Given this list of marker genes LIMCH1, PPM1E, RHPN1, BRAF, RHOC, NF2, SDC4, TAC1, ARHGAP6, TMEFF2, ITGB5, TNFAIP1, EVL, WASF2, RHOA, AMOT, SFRP1, OAZ3, INPP5K, CUL3, PHLDB2, MIR21, S1PR1, ARHGEF5 (Rho guanine nucleotide exchange factor 5), TGFB3, TPM1, LIMK1, SRF, BAG4, WAS, RHPN2, MIR20A, ROCK2, SRC, CARMIL1, PAK2, ARHGEF18, PDCD10, MIR149, PFN1, SMAD3, ITGB1BP1, TACSTD2, CD47, ABL1, CCN2 (cellular communication network factor 2), PPFIA1, ASAP3, FERMT2, ROCK1, PDLIM1, FHDC1, F11R, PIK3R1, ZYX, RAC1, TSC1, PIK3R2, KCTD13, STMN1, ACTG1, DNM2, MYL9, PTGER4, FRMD7, ARHGEF10L, MET, SLC9A1, ITGB1, TESK1, TTC8, ARHGEF15, PAK1, TJP1, CDC42, PHACTR1, ZEB2, LUZP1 (leucine zipper protein 1), ARHGAP28, APOA1, ARAP1, FHOD1, WNT4, ALMS1, EPHA1, ELN, SYNPO, ARRB1, MKKS, SORBS3, BBS4, TACR1, PPM1F, MYOC, ARHGEF10, LPAR1, CGNL1, CCDC88A, DLC1, PXN, SYNPO2L (NCBI Gene Id 79933), NRP1, FAM171A1, CLASP1, RGCC, CLASP2, CORO2B, PFN2, SORBS1, RAPGEF3, MIR138-1, MTOR, SERPINF2, TGFBR1, S100A10, GPR65, RHPN2P1, here is a description of the gene set: species: Homo sapiens Human Gene Set: GOBP_STRESS_FIBER_ASSEMBLY The aggregation, arrangement and bonding together of a set of components to form a stress fiber. A stress fiber is a contractile actin filament bundle that consists of short actin filaments with alternating polarity.